The following is a description of a gene set: Neighborhood of SMARCC1 Neighborhood of SMARCC1 SWI/SNF related, matrix associated, actin dependent regulator of chromatin, subfamily c, member 1 in the GCM expression compendium species: Homo sapiens Human Gene Set: GCM_SMARCC1, and this is the list of marker genes: PNN, GPER1, SRSF2, FUS, DDX18 (DEAD-box helicase 18), TTF1, TLK2, GRM4, MAPRE1, KHDRBS1, FANCC, SF1, TAF11, TIMM17A, DRAP1, TAF9, SMARCD2, MSN, SMARCC1, PDE6B (NCBI Gene Id 5158), DRG2, PTGES3, MIEF1, AIP, PCBP1 (NCBI Gene Id 5093), SLC29A2, MAZ, DHX9, DGCR6, TRAM1, CAPRIN1, DNTTIP2, RENBP, HNRNPL, DDX5, ABCC1, MADD